The following is a description of a gene set: part of: Suppression of phagosomal maturation Lipoarabinomannan (LAM) is transported to Mtb's outer cell wall. When Mtb is interned by the phagocyte, LAM is shedded into the phagocyte's membrane, gets incorporated into lipid rafts of the phagosomal membrane, where it acts to prevent phagosomal-lysosomal fusion. Other processes that get inhibited include the cytoskeletal protein coronin-1A and the fusion mediator vacuolar protein sorting-associated protein 33B (VPS33B). Also the Ras-related protein (Rab5) effector phosphatidylinositol 3-phosphate (PI3P) gets enzymatically depleted. Reactome Pathway: Prevention of phagosomal-lysosomal fusion studied in species Homo sapiens, and this is the list of marker genes: lpdC, esxH, HGS, CORO1A, lprG, UBA52, ndkA, sapM, RAB7A (RAB7A, member RAS oncogene family), UBC, secA2, Rv1410c, RAB5A, RPS27A, ptpA, UBB, VPS33B, esxG